Given this list of marker genes Opa1, Fgf2, Wnt3a, Ep300, Il23a, Nkx6-2, Spdef, Brd2, Brd4, Gfi1, Pax6, here is a description of the gene set: species: Mus musculus Mouse Gene Set: GOBP_POSITIVE_REGULATION_OF_CELL_FATE_COMMITMENT Any process that activates, maintains or increases the frequency or rate of cell fate commitment. Cell fate commitment is the commitment of cells to specific cell fates and their capacity to differentiate into particular kinds of cells. Positional information is established through protein signals that emanate from a localized source within a cell (the initial one-cell zygote) or within a developmental field.